The following is a description of a gene set: Human Gene Set: GSE7831_UNSTIM_VS_INFLUENZA_STIM_PDC_4H_UP Genes up-regulated in plasmacytoid dendritic cells (4h): untreated versus influenza virus infection. from publication Iparraguirre A, Tobias JW, Hensley SE, Masek KS, Cavanagh LL, Rendl M, Hunter CA, Ertl HC, von Andrian UH, Weninger W (PMID 18029397) CpG 1826 binds to Toll-like receptor (TLR)9, whereas influenza virus PR8 activates pDC via TLR7. Differential stimulation of pDCs is expected to result in unique activation mechanism(s) leading to a different phenotypically and functionally matured pDC We used microarrays to detail the global programme of gene expression underlying the maturation process of pDC activated with CpG 1826 and influenza virus PR8. We identified a distinct expression profile of upregulated immunomediators. species: Homo sapiens, and this is the list of marker genes: NELFE, TNFRSF1B (TNF receptor superfamily member 1B), ZFAND5 (NCBI Gene Id 7763), B4GALNT1, HK2, SEMA4A, KCNA7, BCL3 (BCL3 transcription coactivator), SOD1, SCX, AHR, HIF3A, PRRC1, DAO, IHH, RGS2, MYOM2, MSRB1, BTG2, EPB41L2, COTL1, MAN1A1, SNX21, GLRX, SNX10, CDC25C, TGFBI, DIAPH2, CCNA1, APOE (apolipoprotein E), CBFB (NCBI Gene Id 9163), CD300C, TCERG1, KSR1, ARL4C, AP2B1, SLC22A5, BMP1, ELOVL3, CHRNE, EFHD2, BID, PRKCZ, GALR3, GCNT2, MMP12, CACNB3, SLC66A2, PLXNA1, CD81, PRDX1, KIAA0930, PDE6B, MARCKSL1, MAFK, LDB2, CYB5R3, PLA2G7, PCYT1A, CTBP2 (C-terminal binding protein 2), TNFRSF21, ATP5PB, TGM2, KRT71, HSD3B7, NR2C1, CD52, SH3D19, ST3GAL5, PRUNE1, SLC8A1, TES, UQCRC2, HERC4, HLA-DOB, AURKA, SPI1, MDM1, PDE4B, FLNB, JARID2, SMARCD2, PGLYRP1, EPHX2, ADAMDEC1, BFSP1, DSTN, CLIP4, SPRED2, BRAP, SOWAHC, AEBP2, RNASEH2B, LCP1, GPN1, SLC12A7, SLC12A2, HLA-DRA, RALA, VASP, CD302, LYL1, NCF2, EMD, CIB1, DTX1, PAK2, ENTPD1, SLC7A7, CORO1A, RTN1, CSF1R, NPR3, PLD2, PCSK2, CCND1, CTDSP2, THOP1, FCGR2B, CFHR2, KRT33B, BAZ1B, KIT, POLR1A, ADIG, CYP7B1, PPP1R15B, ANXA5, TAP1 (NCBI Gene Id 92050), DKK1, CD63, GSR, FUT7, NRG3 (NCBI Gene Id 219505), DMP1, JUN, MAPRE3, TXNRD1, HLA-G, RBFOX2, RGL2, C9, GFAP, PKP1, ITGAX, MAN2B1, PCBD2, APOBEC1, CD74, LTB, SH3BP1, PSMB9, KIF11, HLA-DRB1 (NCBI Gene Id 730415), ECI1 (NCBI Gene Id 1632), ARHGDIA, SMARCD1, RNF149, KDELR3, MFAP5, GML, CA8, PTPRE, TRAF1, TAF1B, GRB2, ENO3, ITGAV, OAS1, EBI3, RRM2, SBF2, ANXA3, ITCH, SYCP1, LASP1 (NCBI Gene Id 3927), HLA-DOA, CHKA, EEIG1, MKRN3, SQOR, COPA, DNASE1L1, ZBTB22, IFIH1, CTNND2, RBM22, ARHGAP9, TMEM176B, TMEM131, GNB1, HLA-DMB, ZFP2, ECE1, PPP1R21, ITGB5, MDH2, RGL1, RASA4, CHMP5